Given this list of marker genes NLRP3, LRBA, PTH1R, DPP9, SFTPA1, SFTPC, ATP11A, CFTR, HNRNPH1, TGFB1, TLL1, SLCO2A1, ABCA3, MUC5B, RTEL1, FAM13A, PTEN, SLC34A2 (solute carrier family 34 member 2), INTU, DSP, HPGD, NCKAP1L, SFTPA2 (surfactant protein A2), TERT, BMPR1A, PSMB8, PARN, IL21, JAG1, FCGR2A, GJB6, SLC5A6, TERC, CD55, EIF2AK4, RASGRP1, STK11, STN1, HSPG2, here is a description of the gene set: Clubbing of fingers Terminal broadening of the fingers (distal phalanges of the fingers). Human Gene Set: HP_CLUBBING_OF_FINGERS species: Homo sapiens